Given this list of marker genes IMPG2, IMPG1, EYS, RTBDN, RBP3, VCAN, here is a description of the gene set: Human Gene Set: GOCC_INTERPHOTORECEPTOR_MATRIX A specialized extracellularc matrix that surrounds the photoreceptors of the retina and lies between them and the apical surface of the retinal pigment epithelium. The IPM has been implicated in several important activities required for photoreceptor function and maintenance. studied in species Homo sapiens